Given this list of marker genes ANGEL1, COL7A1, SETD4, PNPLA5, VPS26C, NFATC2, WDR41 (NCBI Gene Id 55255), ICAM2, MACIR, CRLF3, NIN, SCLY, TTC32, IFITM10, NACC2, GM2A, SELPLG, PACS2, SMARCA2, PDE2A, IKBKG, HID1, DNAH8, MBP, KIRREL1, MNT, SMC6, PLEKHA1, DCUN1D3, TPST2, CYP2S1, TSC22D3, ACP5, RBM33, IFIT1, AMPD1 (adenosine monophosphate deaminase 1), PPP1R15B, MTRF1L, FRMD8, GPR132, TCP11L2, CRTAM, FLI1, TP53I13, LRATD2, PSEN2, RNF122, SLC16A5, PDCD4, CLYBL, OCEL1, WNT5B, ME2, APOC1, ZBTB2, CNN2, GFRA4, SLC25A44, LIMD1, B4GALT7, HPS3, PACS1, KLHDC2, C19orf12, ITGA6, SFT2D2, ZNF347, ARRB1, NCF4, ELAC1, CYRIA, RPS19, FOLR1, NAGPA, GPD1L, HERPUD1, ZNF212, FOXN2 (forkhead box N2), MOB3B, TAGLN2, RBM48, SIDT1, RIPK2, PLEKHA3, TMX4, ZSCAN25, EFR3A, SPN (NCBI Gene Id 6693), LATS2, CRIP1, ARHGAP1, BIN3, SESN1, CTSD, INPP1, GPR34, ARMC7, TMED8, KLHL21, CMAS, RIPK1, FBXL4, ARFIP1, ELMO1, HTR1B, C3orf38, LENG9, PNPLA7, CALHM6, PRDM1, PRKCZ, ERC2, TMEM9B, CCPG1, PPM1H, CDC14B (NCBI Gene Id 8555), PSMB9, GALNT9 (NCBI Gene Id 729185), MAFK, METTL27, XPC, FAM210B, KIAA1217, NFE2L2, PDE4DIP, NFIC, GPR27, MTSS1, ALOX5, SARAF, EMP3, BSCL2, LRRC23, ANKFY1, SH3KBP1, TOM1, VRK1, RFLNB, BET1L, TAPBPL, CPT1C, MAN1C1, SLC35D2, MOB3A, GABRR2, ZBP1 (NCBI Gene Id 81030), TRIB2, STK17B, MS4A6A, CACNA2D2, LRRC1, CNGA1, MTA3, ZNF217, ARMC3, STON2, RGS6 (regulator of G protein signaling 6), NIPAL3, IRF1, MFSD14A, SETX, CD47, TDRP, NAAA, GIMAP5, DTX1, PATJ, FBXO8, NOD1, SQOR, STAMBPL1, XKR8, OSBPL9, OTULINL, SMG9, RAB37, RRAS, GPR18, ITGB7 (integrin subunit beta 7), ELF1, TEC, F11, CRTC3, CHD7, RBM43, TNFRSF14, DUSP11, SLC39A7, IFI35, ARHGEF11, LFNG, PPM1N, CHD2, RPH3AL, TMIE, IBTK, IDNK, HERC3, PDCD10, RASA3, here is a description of the gene set: from publication Fu W, Ergun A, Lu T, Hill JA, Haxhinasto S, Fassett MS, Gazit R, Adoro S, Glimcher L, Chan S, Kastner P, Rossi D, Collins JJ, Mathis D, Benoist C (PMID 22961053) The transcription factor FoxP3 partakes dominantly in the specification and function of FoxP3+ CD4+ T regulatory cells (Tregs), but is neither strictly necessary nor sufficient to determine the characteristic Treg transcriptional signature. Computational network inference and experimental testing assessed the contribution of several other transcription factors (TFs). Enforced expression of Helios or Xbp1 elicited specific signatures, but Eos, Irf4, Satb1, Lef1 and Gata1 elicited exactly the same outcome, synergizing with FoxP3 to activate most of the Treg signature, including key TFs, and enhancing FoxP3 occupancy at its genomic targets. Conversely, the Treg signature was robust to inactivation of any single cofactor. A redundant genetic switch thus locks-in the Treg phenotype, a model which accounts for several aspects of Treg physiology, differentiation and stability. Genes up-regulated in CD4 T conv over-expressing GATA1 versus GATA1 and FOX3P. species: Homo sapiens Human Gene Set: GSE40274_GATA1_VS_FOXP3_AND_GATA1_TRANSDUCED_ACTIVATED_CD4_TCELL_UP